The following is a description of a gene set: Any process that activates or increases the frequency, rate or extent of integrin-mediated signaling pathway. Human Gene Set: GOBP_POSITIVE_REGULATION_OF_INTEGRIN_MEDIATED_SIGNALING_PATHWAY species: Homo sapiens, and this is the list of marker genes: LOXL3, LAMA2, EMP2, CD63, LIMS1, NID1, FLNA, VTN, LAMA1, LAMC1, LIMS2, LAMB2, LAMB1